Given this list of marker genes Gpx1, Dnajb2, Styx, Psen2, Phf20l1, Hsp90ab1, Oaz1, Herpud1, Ufl1, Vcp, Sh3rf2, Rnf185, Caml, Rybp (NCBI Gene Id 73651), E330034G19Rik, Sirt2 (NCBI Gene Id 80489), Csnk1e, Psmd14, Hamp, F8a (NCBI Gene Id 27589), Bbs7, Ogt, Hspbp1, Fbxw8, Shh, Usp25, N4bp1, Commd1, Kcne2, Fbxw7, Tmx1, Trib2, Usp38, Ubxn2a, Psme3ip1, Fmr1, Plk2 (NCBI Gene Id 20620), Stub1, Dab2ip, Cdc20, Tmf1, Wfs1, Cbfa2t3, Map1a, Tmem259, Nub1 (negative regulator of ubiquitin-like proteins 1), Pabpn1l, Nop53, Csnk2b, Uchl5, Psme1, Psme3, Ttc36 (NCBI Gene Id 192653), Taf9, Axin2, Psen1, Rhbdf1, Gipc1, Gba1, Sumo2, Trem2, Araf, Rchy1, Pabir1, Mapk8, Eif2a, Sgta, Prkn, Aqp11, Mdm2, Nupr1, Wac, Cav1, Clec16a, Cop1, Ern1, Gabarapl2, Rbx1-ps, Mapk9, Apoe, Rybp-ps, Bag5, Xbp1, Hfe, Prickle1, Osbpl7, Sco1, Sumo1, Ubxn1 (NCBI Gene Id 98173), Paqr3, Hspa1b, Dab2, Socs4, Smarcc1, Lrrk2, Trf, Dlgap1, Csnk1a1, Psmd10, Rbx1, Zer1, Desi1, Csnk2a2, Sh3rf3, Foxf2, Zfp418, Dda1, Sh3rf1, Pkd1, Usp14, Dvl1, Usp26, Usp5, Bag2, Ubqln4, Psme2, Sirt1, Trib1, Marchf7 (membrane associated ring-CH-type finger 7), Ubqln1, Bcap31, Pithd1, Gna12, Dnaaf4, Btrc, Gabarap, Cdc20b, Rnf40, Plk3, Tmem67, Glmn, Ubqln2, Nudt15, Alad, Ubb, Lamp3, Aurka, Tlk2, Atg7, Atxn3, Senp1, Fbxo22, Bag6, Zfand2a, Rack1, Usp7 (NCBI Gene Id 98021), Trib3, Mtm1, Ddrgk1, Chfr, Rnf180, Akt1, Sirt6, Svip, Park7, Gclc, Usp13, Rad23b, Tmtc3, Clu, Gsk3a, Plk1, Il33, Ophn1, Socs5, Prkaca (NCBI Gene Id 18747), Rpl11 (ribosomal protein L11), Epm2a, Hspa1a, Prkcg, Klhl40, Fhit, Rnft2, Xpo1, Rnft1, Ccar2 (cell cycle activator and apoptosis regulator 2), Usp9x, Ecscr, Rad23a, Eif2ak3, Usp19, Axin1, Psmf1, Pbk, Nfe2l1, Ube2v2, Eif3h, Zyg11b, Nkd2, Csnk1d, Ube2k, Gsk3b, Wnt10b, Styx-ps, Pias1, Fzr1, Trim39, Det1, here is a description of the gene set: species: Mus musculus Mouse Gene Set: GOBP_REGULATION_OF_PROTEASOMAL_PROTEIN_CATABOLIC_PROCESS Any process that modulates the rate, frequency, or extent of the chemical reactions and pathways resulting in the breakdown of a protein or peptide by hydrolysis of its peptide bonds that is mediated by the proteasome.